Given this list of marker genes CDH6, FAM169A, CAPS2, GADL1, PTPRQ, PDE12, HNMT, SLC35F5, EVI2B, TNRC18, CDK6, KLRC4, RB1CC1, ZKSCAN2, DCLK1, ARPC5, USP31, CUL3, A1CF, BCAP29, KRTAP9-3, TSHR, LCLAT1, TACC1, PLSCR4, FOXO3, PDIK1L, INSYN2A, FBXW11, XRN1, TMEM19, NR2C1, ERCC4, SRFBP1 (NCBI Gene Id 153443), SOAT1, REPS2, ELF1, ZNF207, UBE2L6, UFL1, HLA-DQA1, CADPS, PRDM4, APLN, ARF6, PKIA, NDUFA5, DENND6A, MTMR9, SHTN1, KRTAP9-2, SLC44A5, ATP2C1, SLC4A7 (solute carrier family 4 member 7), SPATA16, BCL2L15, GOSR2, IL17RD, CYSTM1, FKRP, PI15, DNAJC5B, SRSF10, PLEKHA8, PDE4B, CNOT6, ELP1, H2AB2, NNT, MFAP3L, LRRC19 (NCBI Gene Id 64922), TLR8, CLEC4C, NAALADL2, HOXA10, IGF1R, CLPTM1L, ZNF568, LRRFIP2, MYO6, CKS1B, SLC25A47, WDR1, PDS5B, RAP1B, MORF4L2, EMSY, OGN, RPS6KA3, UTY, ATRX, PRRC2B, GIN1, RRAGD, AMOTL1, DNAJC6, TSHZ2, IL5RA, ABHD18, HMGCS1, FSTL5, B3GALT2, ABCC5, JUND, LSM8 (NCBI Gene Id 51691), SNX4, SENP3, GRAMD1C, PRTG, SYNCRIP, TSPAN13, ZBTB8A, DHX33, ZNRF2, TMEM154, ZFHX3, GOLGA6L10 (NCBI Gene Id 728648), NBEA, UBP1, DSG2, MSANTD2, TBL1Y, NAMPT, PCLO, THRAP3, EIF5, COMMD3-BMI1, ELOVL3, GGNBP2, PCDH10, PRKACB, AKAP7, NUTF2, PHOX2B, PPP1R12A, SLC25A40, GALNT2, KMT2A, ZNF543, MEGF9, SLC22A17, SPPL3, FBXL20, CS, TMED2, PUS7L, PRKAR1A, NAB1, CREM (NCBI Gene Id 1390), CNTN3, CGGBP1, PTPN14, SLC6A15, PCDH19, PDS5A, UTP15, NADK2, SEC11A, VGLL3, TBL1X, KIAA1958, SH3RF3, PRKAB2, USO1, ELF2, PTEN, RPRD1A, IQCJ-SCHIP1, FAM114A1, WDR37, SOCS6, RBM4B, ZRANB3, SEMA3A, TCEA1, RWDD4, SZRD1, POF1B, LMO1, GULP1, SLC26A3, EXD2 (NCBI Gene Id 55218), WIPF1, AAK1, ALG8, MINDY2, IKZF5 (NCBI Gene Id 64376), TLR6, TMC1, ALK, CAMK2D, RDH10, TMTC3, RAPGEF5 (Rap guanine nucleotide exchange factor 5), PGR, KLF11, H2AB3, ROCK1, INSC, SAP18, BCORL1, KDM5B, SLC38A9, CXCL5 (NCBI Gene Id 6374), HEPACAM2, PCP4, CLVS2, G3BP1, SOCS5, LRAT (NCBI Gene Id 9227), MBD5, ATAD1, FZD6, TBC1D4, SET, AGO3, UNC80, KDM4C, TMEM135, EML6, SMURF2, GPATCH2L, GCC2, CUL4A, GNG10, SMARCA5, PCSK1, RUBCNL, NOVA1, NHSL3, ATP8A2, TOR1AIP1, KIAA0930, SERPINE1 (serpin family E member 1), HDAC9 (histone deacetylase 9), TFPI, BMP2K, DCBLD2, GABRA1, JAKMIP2, DCP1B, BMPR2, DENND1B, ZDHHC20, GK, NAP1L2, VASH2, SLC7A11, RORA, PDLIM4, MTUS1, NFIB, PPFIA2, DNAJC25-GNG10, ANKRD50 (NCBI Gene Id 57182), PPP2R2B, TDP1, PELI1, PITX2, API5, SLC46A3, CNR1, TACC2, NAV3, C5orf24, TGIF1, HEPHL1, SLC1A2, TAOK3, GPC6, ENY2, AK5, DPYD, ZFHX4, CFTR, SHISA2, MACC1, SHOC2 (SHOC2 leucine rich repeat scaffold protein), H2AB1, KAT6A, STXBP5, SLC30A4, HIVEP1, IL33, F2R, POM121C, PTPN12, SMAD1, LARP1B, ABCC12, MB21D2, ZBTB20, FGF14, ATP8A1, STXBP6, CDKL2, TMX3, ZC3H7A, MYOF, RAD23B, ECT2, NHLH2, GDAP2, AKAP8, MAP4, ZNF233, CERS6, PITPNB, CH25H, DNAJA2, TCERG1L, PIK3R4, GLI3, NR4A3, NPR3, PROS1, ARHGAP5, HIVEP2, DCAF7, SLC39A6, ARHGAP20, PLOD2, CAST, MYLIP, SEPTIN9, VCPIP1, ZBTB10, AGPS, UGT2B17, KRTAP9-8, CHD9, CNBP, SCD5, CWC15, TTI1, ARHGAP11A, SCN1A, WWC3, POM121, DLGAP1, ANKRD22, CXXC4, GPNMB, CSRNP3, CBLL1 (NCBI Gene Id 79872), CNOT6L, SCAF11, APPL1, ARFGAP3, FAM136A, ZBTB41, PRDM6, PDCL3, RFX7, STT3B, EML4, SUV39H2, BRIP1, COBL, ROBO2, ZSCAN23, CLTA, SPSB4, RAB27A, PRR14, PRSS27, NPHS2, SCGB2B2, PGAP1, NADK, AGAP1, ZFX, TNPO3, ANKS1B, TEAD1, PHF8, USP15, CMPK2, MTX3, GPR158, ZXDB, ADCY7, here is a description of the gene set: studied in species Homo sapiens from publication Chen Y, Wang X (PMID 31504780) Genes predicted to be targets of miRBase v22 microRNA hsa-miR-494-3p in miRDB v6.0 with MirTarget v4 prediction scores > 80 (high confidence targets). Human Gene Set: MIR494_3P